Given this list of marker genes ATP6V0A2, ADAR, RNASEH2C, TRAPPC4, KCNJ6, TBCK, SLC39A8, POMT2, TREX1 (three prime repair exonuclease 1), RAB18, MECP2, GRIN1, PRUNE1, CDKL5 (NCBI Gene Id 6792), SAMHD1, PCDH12, DIAPH1, AIMP2, IDS, FGF12, VARS1, FAR1 (fatty acyl-CoA reductase 1), WASHC4, SMS, CHD8, CNPY3, CLIC2, PAFAH1B1, PCDH19, VPS53, UBTF, PDHA1, UGP2, UNC80, ARV1, SPTAN1, WARS2, TBC1D20, EMC1 (NCBI Gene Id 23065), FKRP, BUB1B, SETD1B, AP1S2, P4HTM, PIGU (NCBI Gene Id 128869), HSPD1, SLC9A6, NSF (NCBI Gene Id 4905), RNF113A, PUS3, DPYD, CRPPA, MRAP, RNU7-1 (NCBI Gene Id 100147744), OCLN, OFD1, GUF1 (NCBI Gene Id 60558), TBCD, PIK3R2 (NCBI Gene Id 5296), FKTN, ADAM22, POMGNT1, DPH5, PIGG, STRA6, NUP133, LONP1, DMXL2, NACC1, LARGE1, NDE1, TBC1D2B, ST3GAL3, ZNHIT3, STXBP1, PIGA, RNASEH2B, SLC16A2, SCN1A, NAPB, CCDC88A, PRPS1, FH, SLC1A2, ELOVL4, CACNA2D1, NGLY1, IER3IP1, GAD1, PIGP, ASXL1, RNF13, EXOSC5, ATP6V1A, DPM3, SYNJ1, RNASEH2A, FGFR3, ASXL3, SEPSECS, SCN8A, ERCC6, ATP6V1E1, ATIC, ATP6V0C (NCBI Gene Id 527), IFIH1, MED23, POMT1, LSM11, WDR45B, here is a description of the gene set: Human Gene Set: HP_INTELLECTUAL_DISABILITY_PROFOUND studied in species Homo sapiens Intellectual disability, profound Profound mental retardation is defined as an intelligence quotient (IQ) below 20.